The following is a description of a gene set: Human Gene Set: HAMAI_APOPTOSIS_VIA_TRAIL_UP studied in species Homo sapiens Genes up-regulated in T1 cells (primary melanoma, sensitive to TRAIL) compared to G1 cells (metastatic melanoma, resistant to TRAIL). from publication Hamaï A, Richon C, Meslin F, Faure F, Kauffmann A, Lecluse Y, Jalil A, Larue L, Avril MF, Chouaib S, Mehrpour M (PMID 16983347) In order to define genetic determinants of primary and metastatic melanoma cell susceptibility to tumor necrosis factor-related apoptosis-inducing ligand (TRAIL), we have applied oligonucleotide microarrays to TRAIL-sensitive primary T1 cells and TRAIL-resistant metastatic G1 cells treated or not with TRAIL. T1 and G1 cells are isogenic melanoma cell subclones. We examined 22 000 spots, 4.2% of which displayed differential expression in G1 and T1 cells. Cell susceptibility to TRAIL-mediated apoptosis was found to be correlated with gene expression signatures in this model. Some of the differentially expressed genes were identified as involved in ATP-binding and signaling pathways, based on previously published data. Further analysis provided evidences that c-kit was overexpressed in G1 cells while it was absent in T1 cells. The c-kit inhibitor, imatinib, did not restore TRAIL sensitivity, excluding a role for c-kit in TRAIL resistance in G1 cells. Surprisingly, imatinib inhibited cell proliferation and TRAIL-mediated apoptosis in melanoma cells. We investigated the possible involvement of several molecules, including c-ABL, platelet-derived growth factor receptor (PDGFR), cellular FADD-like interleukin-1 alpha-converting enzyme-like inhibitory protein (c-FLIP)(L/S), Fas-associated DD kinase, p53, p21(WAF1), proteins of B-cell leukemia/lymphoma 2 (Bcl-2) family and cytochrome c. Imatinib did not modulate the expression or activation of its own targets, such as c-ABL, PDGFRalpha and PDGFRbeta, but it did affect the expression of c-FLIP(L), BCL2-associated X protein (Bax) and Bcl-2. Moreover, c-FLIP(L) knockdown sensitized T1 cells to TRAIL-mediated apoptosis, with a sensitivity similar to that of cells previously treated with imatinib. More notably, we found that the resistance to TRAIL in G1 cells was correlated with constitutive c-FLIP(L) recruitment to the DISC and the inhibition of caspase 8, 3 and 9 processing. Moreover, c-FLIP(L) knockdown partly restored TRAIL sensitivity in G1 cells, indicating that the expression level of c-FLIP(L) and its interaction with TRAIL receptor2 play a crucial role in determining TRAIL resistance in metastatic melanoma cells. Our results also show that imatinib enhances TRAIL-induced cell death independently of BH3-interacting domain death agonist translocation, in a process involving the Bax:Bcl-X(L) ratio, Bax:Bcl-X(L)/Bcl-2 translocation, cytochrome c release and caspase activation. Our data indicate that imatinib sensitizes T1 cells by directly downregulating c-FLIP(L), with the use of an alternative pathway for antitumor activity, because PDGFRalpha is not activated in T1 cells and these cells do not express c-kit, c-ABL or PDGFRbeta. Caspase cascade activation and mitochondria also play a key role in the imatinib-mediated sensitization of melanoma cells to the proapoptotic action of TRAIL., and this is the list of marker genes: B3GALNT1, ZNF12, CDH19, DNAJA4, RALBP1, KNL1, HAUS6, FAP, NMD3, SPG11, EMP1, NMI, FAHD2A, ITPR2, BMP7, RFC1, MYO9A, RALA, ZNF138, NAP1L1, RAB27A, RAD50, ZNF654, OSBPL1A, PROS1, MYO6, L1TD1, SON, TCF4, CDC42BPA (CDC42 binding protein kinase alpha), FSTL1, SRSF11, CD55, ITPR1, RNMT, TATDN1, CHORDC1, GKAP1, TTK, RCN2, NAA15, CCK, RETREG1, HMMR, FST, CASP8AP2, ASPM, ATP6V1E1, RAD54B, TRPM1, ZNF302, MTUS1, SCAF11, MITF, PDCD10, SH3BGRL (SH3 domain binding glutamate rich protein like), RWDD1, DCT, USP47, CEP70, FAM111A, RNF20, MPHOSPH8, CLDN1, ZNF271P, EIF5B (eukaryotic translation initiation factor 5B), PCCA, TCEAL2, DCLRE1C, DEK, NT5C, ZNF644, RAMP1, VRK1, ASRGL1, HAS2, NDUFS4, IARS1, ICE2, CSPP1, CTSV, REV3L, HDAC2, SPP1, G0S2 (NCBI Gene Id 50486), TRIM24, CAPRIN2, PLXNC1, UFL1, TCIRG1, KTN1, ZNF611, PHAX, OMA1 (OMA1 zinc metallopeptidase), CDH1 (cadherin 1), CENPU, TNFRSF6B, TRIM63, NKAP, WWP1, KCNJ5, SREK1, CSGALNACT2, KIF5B, SLU7, NUDT12, BRCA1, TRAPPC8, FGF13, EXOC3, PPP2R3A, IPO5, LUC7L3, PI4K2B, DDX21 (NCBI Gene Id 9188), KIF23, USP25, WBP4, ENPP2, FBXO25, GAREM1, NUSAP1, SNAPC1, TCAF1, PUM3, KIF15, CEP290 (centrosomal protein 290), LRRC40, RBM17, AP1S2, ARID4B, MOXD1, TCEAL3, SMPDL3A, MIS18BP1, ITFG1, XRCC4, PPIG, CEBPZ, ASAH1, BCLAF1, HAUS3, LYPLAL1, PIEZO2, RECQL, TBC1D9, IFT74, IQGAP2, ARFGAP1, TAOK3, EIF1AX, ACADM, DNAJB14, TRMT10C, ITGB1, SMARCA2, MLANA, NPM1, KRR1, EIF3A, LLPH, CEP192, MSH3, LINC01949, CENPC, SNX13 (NCBI Gene Id 23161), TDRD3, DCUN1D1, ORC3, BRIX1, ARHGAP44, CELF2, ITSN2, RBM26 (NCBI Gene Id 64062), DLGAP5, TBCA, WRN, ELSPBP1, EIF3E, OSBPL8, RABGAP1L, OLFM1, KRIT1, LIG4, SLC27A3, SFTPC, ERGIC2, PHF20L1, COG6, CCDC112, C15orf48, PALLD, ZNF486, SDAD1, USP12, IFI16, HSPB2, ANKHD1, RSF1, ZHX1, HSP90AA1 (NCBI Gene Id 89272), EMC2, PPP4R2, SSB, RRM2B, SMCHD1, BPTF, CETN3, TRAPPC13, CAST, ZNF195, SPDL1, GOLGA4, SUCO, SCP2, LGALS8, SETX, CALD1, PHF3, TMSB15A, FMOD, MATN2, COL25A1, NRGN, MPHOSPH10, ZNF43, OSBPL10, LINC00467, PUS7L, ZBTB11, MYCBP2, CTSZ, ZNF83, HIPK2, ARHGAP10, TENT5A (NCBI Gene Id 55603), ARFGEF1, EIF4EBP3, C1GALT1, IDI1, SLC35G2, MYO10, GLIPR1, DBF4, MAPK6, AGGF1, GGH (gamma-glutamyl hydrolase), ATXN3, TDRD7, SLC24A3, TASOR2, MSH2, ZNF107 (zinc finger protein 107), EEA1, RPAP3, DEPDC1, CEP57, ATL1, LAYN, PDGFRL, CREB1, SLMAP, ARMC1, TPD52, PDS5B, PNISR, NBN, CENPE, CEP350, AGTPBP1, CLIP1, RPS6KC1, STAT1, FXYD6, AP1AR, MGAT4A, HSP90B1, DHX29, STXBP3, ZNF148, MYBL1, PIK3CA, PBK, SLC39A6, TUT4, EXOC1, DTWD1, ZNF407, XPO1, SLC38A2, CPLANE1, CUL2, BUB1B, USP48, NIPBL, SPECC1, ARMCX3, RIF1, MMD, ADAM9, OBI1, ETAA1, RB1CC1, FRA10AC1, NEK1 (NIMA related kinase 1), ST3GAL1, ATR, FXR1, THAP1, TOP2B, TMF1, DNAJC13, CCNL1, AHI1, ZNF137P, NARS1, PHGDH, TMEM167A, DNAJC1, MTR, QSER1, TAF9, DPP4, TTLL7, SORL1, RAPGEF6, ITGA6, SNX2, CWC27, SMS, FBLN5 (NCBI Gene Id 11268), ZNF638, BLZF1, PIR, SKAP2, ENOX2, DYNC2I1, PKIB, UCHL5, COL9A3, SEMA3C, PENK, ADD3, MNAT1, LRRC4, ZXDA, EPRS1, RABEP1, ZNF22, TAX1BP1, ITM2A, BBX, AHCTF1 (NCBI Gene Id 442770), KIF14, LACTB2, THBD, SEC62, CENPH, YEATS4, ZDHHC11, JAKMIP2, PODXL, ZCRB1, ECHDC1, RAD51AP1, CCDC47, SPESP1, OPTN, BNIP3L, CTNNAL1, TNPO1, ORAI3, TBK1, KIT, TRIM2, CCDC88A, RPGR, ABCA5 (ATP binding cassette subfamily A member 5), MAP3K2, OSTM1, TM7SF3, IGFBP4, SLC16A7, FBXL3, SCOC, PRPF4, FPGT, TRIM33, CENPQ, APC, ERCC5, ZNF257, SLK, PSMD12, NUF2, CEP63, COLQ, USP8, GTF2H2, ZZZ3, SYNE2, VPS41, DDX46, ITGAV, CEP112, ZNF268 (NCBI Gene Id 10795), SKIC3, VPS26A, HSPH1, ASB5, DDX10, ZNF85, SLC4A1AP, PRPF38B, CENPK, DNAJA1, UPF3A, PCM1, DNM1L, CTTNBP2, PPFIA1, ZNF354B, TAF1B, FYB1, CEP55, TRIP11, RSRC2, NKTR, ZNF430, CWF19L2, DNAJB11, STRBP, MFAP1, CDK5RAP2, ZCCHC2, NDC80, ZMYM1, CTNND2, N4BP2L2, GCC2 (NCBI Gene Id 9648), TCEAL9, SERPINF1, GPALPP1, PIBF1, TUT7, WASHC5 (NCBI Gene Id 9897), LUM, ZBTB38, NIN, MNS1, GPBP1, CROT, EXT1, CHST9, SLC30A5, FER, BASP1, HSPA4L, MGLL, MTREX, LIMA1, BLM, SMC4, SMC6 (structural maintenance of chromosomes 6), BIRC2, CLEC2B, ATAD2, POLQ, BAZ1A, APPL1, MICU2, DNAJC3 (DnaJ heat shock protein family (Hsp40) member C3), BCAP29, MBD4 (methyl-CpG binding domain 4, DNA glycosylase), KIF18A, MYEF2, SLC45A2, JAG1, ATM, PLS3, CHD1, CUL4B, PPWD1, TCEA1, UBE3A, MYH10, ZNF700, CCNH, CCDC91, SMARCAD1, ARHGAP11A, RIOK2, SCML1, NCL, NFIB (nuclear factor I B), DNAJC7, METAP2, GPR27, LARP7, DHX36, SSPN, RAD17, THUMPD3, ANLN, SULT1C2, SULF2, NEMF, SNAP25, SEC63, ZNF443, ATF7IP, GNPTAB, RAD21, HPGD, PARPBP, FAM13B, FERRY3, GGNBP2, STX7, SNX16, PYROXD1, SMC3, PAPSS2, BAZ1B, KNTC1, FNBP1, ITGB3BP, ZCCHC9, DOCK10, MKI67, SPINK1, ZNF117, ZNF146, KIF11, HECTD1, GALNT1, RMI1, IWS1, DMXL1, PBRM1, CCAR1, DYNC1I1, RBM27, NOX4, RDX, MYO5A, ENAH, ALDH2, CEP170, USP1, MTDH, PJA2, MOSPD2, SMC2, IFIH1, ZC3H8, GPM6B, WDHD1, AP3B1, CHMP2B, RORA, DPP8, PRPF39, HMGB1, ARMT1, PPIP5K2, ARHGAP5, WDR11, BTBD7 (BTB domain containing 7), GTF2F2, EPB41L3, OPA1, ESRRG, EIF3J, SNX10, SACM1L, TTC1, PNN, GPR19 (NCBI Gene Id 2842), TCEAL4, PTEN, RINT1, HLTF, CBX3, VPS13C, RBBP8 (NCBI Gene Id 5932), BRCC3, RLF, KIF20B (NCBI Gene Id 9585), BHLHE41, DAAM1, KIF16B, RESF1, HTATSF1, VLDLR, CFAP36, SACS, DZIP1, ECT2, MRPS31, BAZ2B, BCCIP, HELLS, BDP1, EIF2S2, POLK, PPARGC1A, RAD18, NUCB2, TASOR, SUZ12, NRIP1, RNF13, PAIP1, PCSK5, DIAPH3, STOX2, DYNLT3, GOLGB1, DNAJC8, ATOSA, GOLIM4, ZNF397, NPDC1, KIAA0319, CTHRC1, PSMA4, ESF1, KIDINS220, SLF1, USP9X, NID1, KIF3A, SHTN1, PPIL4, ATP1B1, NPIPB3, SOCS3 (suppressor of cytokine signaling 3), RNF145, RUBCNL, STAG2, MID1, ADGRG1, NAP1L3, ST6GALNAC1, RAI14, MTERF3, PTPN13, NOC3L, AIMP1, CCDC59 (coiled-coil domain containing 59), CDC5L, IGF1, BCAS2, NSRP1, AKAP11